The following is a description of a gene set: Human Gene Set: MIR3177_5P species: Homo sapiens Genes predicted to be targets of miRBase v22 microRNA hsa-miR-3177-5p in miRDB v6.0 with MirTarget v4 prediction scores > 80 (high confidence targets). from publication Chen Y, Wang X (PMID 31504780), and this is the list of marker genes: SMURF1, SEC63, MOAP1, RASD2, TAB3, BRINP1, GRN, TP53INP1, INSYN2A, PTPRF, VPS13C, UBE2K, SLC24A2, MAGI3, BCL2L14, OCIAD2, FHOD3, SYT16, RSPRY1, CHD1, PPM1G, SORCS3, PTBP2, FGF7, ZNF10, RHOQ, HMGXB4, ACADM, RCSD1, ZNF559, CNKSR3, CORO2B, RP2, NCAM2, EPHA4, USP10, ZNF273, DKK1, IGFL2, GRAP2, STAT6, GSK3B, ZNF716, LTBP3, ENKD1, FOXD3, BAG2, HBP1, MAPK6, PSMC2, ZNF254 (NCBI Gene Id 9534), ABCE1, GK, SLC24A3, AUTS2, RPS3, UCHL5, NMBR, WNK1, DKK2, CYP1A1, ZNF43 (zinc finger protein 43), GNAI1 (G protein subunit alpha i1), RNF138, FABP2, SELENOI, YY1, INTS8, SET, PAPOLG, STXBP5L, CD58, GPSM2, HTR7, HSPA4L, ZNF708, KCNC1, LRRC8C (NCBI Gene Id 84230), PPP1R3C, PYGB, SAT1, TBC1D8B, WWC3, DYNLT5, CYP20A1, RAD51AP2, CDH2 (cadherin 2), STEAP4, JADE1 (jade family PHD finger 1), ADD3, KDM5A, PRR12, RLF, CUBN, RPL28, MEA1, NUP160, ATXN7, ZNF681, GOLM1, ELL, PCDH18, NTN1, STRAP, PAMR1, PTCHD4, GNB4, FNIP1, ANKMY2, ATP2B2, MAPK9, ZNF430, ATOH7, UNC5A, TRAT1, ZNF749, ATP11A, SLC2A11, ASXL1, PUS7, TCHHL1, AKT3, POU3F1, NAA16, ENOPH1, PHF12, THBS1, RNF38, ZNF143, CASTOR2, B3GNT9, SNTA1, ARPC3, BCL2, MEMO1, PLPPR1, FPGT, SPTLC1, ADAMTS3, CBX4, LMBR1, GATA6, HIC1, ZNF117, EIF5A2, GLCE, ZNF208, ZNF92, ZNRF3, GRHL1, CCDC186, RANGAP1, PPP1R3B, ZNF257, TBC1D23, PCBD2, GABPB1, CTLA4